The following is a description of a gene set: To investigate the early host response triggered by three different strains of Trypanosoma cruzi at a local infection site, changes in host gene expression were monitored in a murine intradermal infection model using Affymetrix oligonucleotide arrays. Robust induction of IFN-stimulated genes (ISGs) was observed in excised skin 24 hours post-infection where the level of ISG induction was parasite strain-dependent with the least virulent strain triggering a muted IFN response. Infection of mice immunodepleted of IFNγ-producing cells or infection of IFNγ-deficient mice had minimal impact on the IFN response generated in T. cruzi infected mice. In contrast, infection of mice lacking the type I IFN receptor demonstrated that type I IFNs are largely responsible for the IFN response generated at the site of infection. These data highlight type I IFNs as important components of the innate immune response to T. cruzi the site of inoculation and their role in shaping the early transcriptional response to this pathogen. We used microarrays to detail the local host transcriptional response to intradermal T. cruzi infection in WT mice and mice depleted of NK cells, or deficient in IFN-gamma or type I IFN responses. Additionally we compared the local host-transcriptional response generated to infection with 3 different strains of Trypanosoma cruzi (Y, Brazil, and G). from publication Chessler AD, Unnikrishnan M, Bei AK, Daily JP, Burleigh BA (PMID 19201883) Human Gene Set: GSE13522_WT_VS_IFNG_KO_SKIN_UP Genes up-regulated in skin from: wildtype (BALB/c) versus IFNG knockout. studied in species Homo sapiens, and this is the list of marker genes: OOSP1, ADAM33, EPO, DMBT1, SEMA6B, RNF150, KCNK1, ETV2, SARDH, TMEM17, TBCEL, LYPD9P, SEC31B, DNAJC5G, PWWP3B, SLC47A2, NKX3-1, RSPH6A, EPHA7, CEACAM18, C14orf39, CRYBA4, CXCL5, LTBP2, UNC80, KCNK4, SPAG11B, PABPC5, KCNJ3, PPP1R3D, CAVIN4, SLC20A1, CAV3 (NCBI Gene Id 859), HCAR2, PRSS48, NRG2, TAAR2, GLDN, DRD5, DSC3, KRTAP4-7, MPTX1, GSC2, ART3, STEAP2, ADAMTS10 (ADAM metallopeptidase with thrombospondin type 1 motif 10), ARL16, RNF186, KIFC2, NEK5, TIE1, KLF17, CSN1S2AP, HCN3, NLRP3, AWAT2, ENAM, KLF14, SERPINA12, GPR137C, DIP2C (NCBI Gene Id 22982), HCN1 (NCBI Gene Id 609), L1TD1, ITM2A, RBM46, C10orf120, DSCAM, CNTN2, C22orf39, RNF222, GABRP, TMEM253, NEUROD2, MIR202, HCK, DES, CPLX3, CHRNA5, CDKN3, NRG3, SULT4A1, FSTL5, ADAMTS13, ARHGAP40, OXT, PRR5, VWA2, KIDINS220, UGGT2, TNNI3, ACR, FTMT, DPYSL3, ITIH4, TMEM45B, VAMP1, ZDHHC19, COL14A1, RPL7A, DCX, DIO2, FERD3L (NCBI Gene Id 222894), TMEM270, FOXI1, ANKFN1, MAB21L1, CLU, HPS3, LMTK3, NOL4, RERG, CCNB3, FZD3, UPK2, CLIC3 (chloride intracellular channel 3), TAL1, GPR27, PARVB, MIR99B, ROBO1, CNTN3, CLEC1A, CACNG3, CCDC172, TMC6, CYP26B1, EPHA1, ADRB3, SHISA6, MAPK4, BAIAP3, LRRC56, EBF4, PHKA2, DHTKD1, MTFP1, CNR2, SPAG6